The following is a description of a gene set: species: Homo sapiens Human Gene Set: GOMF_BILE_ACID_TRANSMEMBRANE_TRANSPORTER_ACTIVITY Enables the transfer of bile acid from one side of a membrane to the other. Bile acids are any of a group of steroid carboxylic acids occurring in bile, where they are present as the sodium salts of their amides with glycine or taurine., and this is the list of marker genes: ABCC3, AKR1C4, SLCO2B1, SLCO1B7, SLC10A5, SLC10A4, SLCO1C1, ABCC4, SLCO1B1, SLC10A2, SLC10A6, SLC10A1, SLC10A3, SLC51A, CEACAM1, SLC51B, SLCO1B3-SLCO1B7, SLCO1A2, ABCC11, ABCB11, SLCO1B3